The following is a description of a gene set: species: Homo sapiens Prolactin signaling Human Gene Set: WP_PROLACTIN_SIGNALING, and this is the list of marker genes: RAC1, SHC1, SOCS2 (suppressor of cytokine signaling 2), NOS2, IRF1, RPS6KA2, SIRPA, PTPN11, STAT3, MAPK1, GAB2, RAF1, NFKBIB (NFKB inhibitor beta), JAK1, RPS6KB1, GRB2, IRS2, SRC, MAP2K2, CBL, SOS1, PIK3CA, ELK1, ZAP70, CTSD, STAT1, STAT5A, HRAS, FYN, GSK3B, RPS6, PAK1, PIK3R1, MAPK8 (mitogen-activated protein kinase 8), CISH, NFKBIA, PIK3R2, TEC, VAV1, PIK3CG, PPIB, IRS1, PRLR, AKT1, RELA, FLNA, SOCS3, EIF4EBP1, NFKB1, PTPN1, PIK3CB, MAPK3, PTK2, YWHAG, MAP2K1, MTOR, ITGB1, CASP3, FOS, AGAP2, PXN, PTPN6, NEK3, VAV2, YWHAZ, MYC, PRL, PIAS3, ERBB2, MAPK14, JAK2, MAPK9, PPIA, JUN, SOCS1, STAT5B